Given this list of marker genes ERCC8, CDC34, UNC93B1, CCL7, SUCLG1, HBEGF, DDX18, HNRNPAB, MRPS33, COX6A1, WDR18, ZMAT3, LAMP1, AEN, JAM2, NECTIN2, CTSD, ACP2, USP36, SSR4, MRPS27, IPO9, IFT43, ZNF318, ODC1, MRTO4, PLAUR, P4HA3, PRELID1, FCGR1A, LIPG, SPRED1, CEP170B, TSR1, PLXNA1, LRP12, F2RL2, MRTFB, WARS1, GCSH (NCBI Gene Id 2653), AKAP1, POLR3H, SLC52A3, DHX33, EMP2, CD248, TULP4, SOCS5, GPR84, ATP6V0E2, DOCK4, MFHAS1, ENO1, NDUFS8, HNRNPC, SERPINB2, SLC38A4, PVT1, TMEM237, TIMM10, PPA1, CCDC80, TMEM238, C7orf50, EFHD2, SMYD2, TMLHE, C3AR1, UQCRQ, PRPF31 (NCBI Gene Id 6106), TMEM86A (transmembrane protein 86A), CCDC134 (coiled-coil domain containing 134), SNUPN, ASS1, CD302, APEX1, SLC39A2, CKM (NCBI Gene Id 95741), COMT, RNH1 (ribonuclease/angiogenin inhibitor 1), SQLE, ZNF846 (NCBI Gene Id 162993), KCTD17, NOB1, NME2, LFNG, NRP2, FBXO6, WDR81 (WD repeat domain 81), CD274, SDHAF2, SPRYD4, AKR1E2, ATP13A2 (ATPase cation transporting 13A2), SKI, ARHGDIA, SDF2L1, RRN3, FNIP2, DCTPP1, MTG1, DAG1, SIGMAR1, COQ3, RPS26, MTX1, SH2D1B, ITFG2, SHTN1, SERPINB8, DIP2C, CNNM2, COMMD9, SLC1A5, SERF1A, OPN3, NR4A3, TXNRD1, BHLHE40, LPP, ALDOA, PTK2, METTL1, PINX1, RPS8, RANBP1, POMP, NAB2, CDH17, RPL19, RDH13, PLPP2, SUPV3L1, RHOQ, CD38, MYCL, SMPDL3B, CFP, TMBIM1, CLTA, CBX2, CCL4, CCBE1, MTSS1, CD53, LGALS3 (galectin 3), ACOD1, TMEM167A, B3GNT2, TUFT1, EPS8, TNIP1, PLEKHM2, SLC25A39, LRPAP1, DDB1, DUSP19, ATP5MC3, COL23A1 (NCBI Gene Id 91522), TGIF1, PTGS1, UQCR10, SNAI3, CCDC137, PABPC1, IGF2BP2, EIF3B, ANPEP, SNX3, TRIM13, CBR3, ATIC, CYB561A3, A2M, TREM2, ZFP36L1, SCIN, CCND2, IER3, ECE2, DHCR24, RPS19, ATP5F1B, YARS1, PCED1A, SLC19A1, MRPS24, PWP2, KCTD5, EBPL, SELENOW, CDH1, MYO1E, SERP1, GORASP1 (golgi reassembly stacking protein 1), HGFAC, MREG (melanoregulin), KCNN4, UQCC2, LGALS1, here is a description of the gene set: Three innate (B1-B, NKT, CD8aaT cells) and adaptive (B2-B, CD4T, CD8abT cells) cell-types were sorted by FACS. Three biological replicates for NKT, CD4T, CD8aaT, CD8abT cells and two biological replicates for B1 and B2 cells were generated and the expression profiles were determined using Affymetrix Mu74Av2 chip. Comparisons between the sample groups allow the identification of genes differentially expressed between the innate and adaptive cell-types. from publication Yamagata T, Benoist C, Mathis D (PMID 16623764) Genes down-regulated in CD4 T cells versus B2 B lymphocytes. Human Gene Set: GSE3039_CD4_TCELL_VS_B2_BCELL_DN studied in species Homo sapiens